Given this list of marker genes Akap9, Rnf10, Dgkb, Olfm2, Tiam1, Fgf22, Scrib, Cnksr2, Dgki, Olfm1, here is a description of the gene set: Mouse Gene Set: GOCC_EXTRINSIC_COMPONENT_OF_POSTSYNAPTIC_DENSITY_MEMBRANE species: Mus musculus The component of the postsynaptic density membrane consisting of gene products and protein complexes that are loosely bound to one of its surfaces, but not integrated into the hydrophobic region.